The following is a description of a gene set: species: Homo sapiens Murine Cytomegalovirus (MCMV) infection leads to early activation of various immune cells, including B and T lymphocytes, before the actual initiation of antigen-specific adaptive immunity. This activation is partly driven by innate cytokines, including type I interferon (IFN), which are induced early after infection. The objective of this study was to address the role of type I IFN in shaping early/innate B and T cell responses to a primary acute viral infection. In order to decipher the specific impact of IFN-I on cell subsets, we performed a genome-wide expression analysis on WT splenic B and CD8 T lymphocytes isolated from C57BL/6 mixed bone marrow chimera mice. This study complements series GSE39555, which focused on early responses of NK cells and of the two subsets of conventional dendritic cells. Genes down-regulated in ITGAM+ dendritic cells: control versus primary acute viral infection. Human Gene Set: GSE45365_HEALTHY_VS_MCMV_INFECTION_CD11B_DC_DN, and this is the list of marker genes: DLGAP5, HJURP, PPBP, AURKA, ZMAT5, CDCA3 (cell division cycle associated 3), F3, HSD3B7, OR4D2, SAA4, ASPM, ATP8B3 (ATPase phospholipid transporting 8B3), CENPA, SSX1 (SSX family member 1), KIF20A, ZC2HC1C, GREB1L (NCBI Gene Id 80000), ZNRF2P1, DYNC2LI1, TSGA10, KCNMA1, PLK1, GSTA3, SH3BP5L (NCBI Gene Id 80851), SEPHS2, NAV3, ZNF488, FAM89A, AURKB, SUSD5, DIAPH3, HTN1, SPATA31F2P, MIR503HG, MS4A4A, OR5P3, DTL, CCNA1, BBS5, H2BC12, PTTG1, RTL9, ZNF619, CENPE, HISLA, HPYR1, FOXM1, SYNC, M1AP (NCBI Gene Id 130951), BIRC5 (baculoviral IAP repeat containing 5), TAC1, ATP8B5P, DNAH14, ITGA2B, LINC01692, MGLL, STIMATE, MIEF2, MAGEA4, SPAG5 (sperm associated antigen 5), PCK1, MPIG6B, NEK2, KIF27, SLIT3-AS1, MTFR2, UBE2C, SHCBP1, LSM1, AIG1, LL22NC03-63E9.3, TREML1, CXCL6, PROS1, NUF2, SLITRK2, PF4 (platelet factor 4), CEP55, CAV1, C9orf152, PTGR1, CTSG, CCNB2, CALM3, SLC25A48-AS1, PCLAF, GGH, GNA14, MARCHF2, BROX, SKA3, MKI67, ZNF662, FAM89B, MPST, TPM1, PRTN3, CENPN, CLDN1, GJA1 (gap junction protein alpha 1), CENPF, CCNB1, ADAT3, RAB39A, TTC7B, NNMT, H4C11, GUCY1A1, CLEC1B, STXBP6, UBE2S, ZFHX4, SELP, PIR, TMT1B, CHAC1, GINS1, PLAC8, GRM6, CCDC140 (CCDC140 long non-coding RNA), CDKN3, MED18, LRRTM4, CDCA8, RILPL1, ANLN, L3MBTL4 (L3MBTL histone methyl-lysine binding protein 4), PSAT1, KDELR3, HMMR, NEURL1B, MEIG1, MYL9, TMEM201, TPX2 (TPX2 microtubule nucleation factor), TBX19, CBLN2, TYRP1, TECTB, SIRPD, SLC25A31, MTCL1, PCDHB4, TRHDE, TBX22, LINC00470, KIF18B, UPK1A, LMBRD2, TMSB15A, MYL6B, TRIM36, G6PD, GSTM5, DHCR7, CYS1, TROAP, LINC01579, PBK, PRC1, TRIP13, CDCA5, TK1, LUM, SLC7A9, PXDNL, CRYAB, ZNF789, RRM2, MELK, TCEANC2, GP1BA, ITGB3, ESCO2, GPRC5D, PLOD2, ALOX12, ENSG00000257176, UFD1, PTCHD3P1, LINC00315, HSPA2, GPR19, TUBG1, MAP10, CD63, C1orf226, CDC20, C11orf71, CDK1, MYO10, CMTM5, DEPDC1, RGS22 (NCBI Gene Id 26166)